The following is a description of a gene set: Human Gene Set: GOBP_DETECTION_OF_TEMPERATURE_STIMULUS_INVOLVED_IN_SENSORY_PERCEPTION_OF_PAIN The series of events involved in the perception of pain in which a temperature stimulus is received and converted into a molecular signal. studied in species Homo sapiens, and this is the list of marker genes: SCN11A, SCRN3, TAC4, PRDM12, SCN9A, ADORA1, ASIC3, NR2F6, HTR2A, NTSR1, TAC1, CXCL12, MMP24 (NCBI Gene Id 10893), LXN, DISC1, ANO1, NTRK1 (neurotrophic receptor tyrosine kinase 1), COMT, EPHB1, TRPV1